The following is a description of a gene set: Genes containing one or more binding sites for (Smyd5) in their promoter regions (TSS -1000,+100 bp) as identified by GTRD version 20.06 ChIP-seq harmonization. Mouse Gene Set: SMYD5_TARGET_GENES from publication Yevshin I, Sharipov R, Kolmykov S, Kondrakhin Y, Kolpakov F (PMID 30445619) species: Mus musculus, and this is the list of marker genes: Tex14 (testis expressed gene 14 intercellular bridge forming factor), Eapp, Gprin1, Snord3a (small nucleolar RNA, C/D box 3A), Mir6236, Gm15564, Scrt1, Gtf3c6